The following is a description of a gene set: species: Mus musculus We combined large-scale mRNA expression analysis and gene mapping to identify genes and loci that control hematopoietic stem cell (HSC) function. We measured mRNA expression levels in purified HSCs isolated from a panel of densely genotyped recombinant inbred mouse strains. We mapped quantitative trait loci (QTLs) associated with variation in expression of thousands of transcripts. By comparing the physical transcript position with the location of the controlling QTL, we identified polymorphic cis-acting stem cell genes. We also identified multiple trans-acting control loci that modify expression of large numbers of genes. These groups of coregulated transcripts identify pathways that specify variation in stem cells. We illustrate this concept with the identification of candidate genes involved with HSC turnover. We compared expression QTLs in HSCs and brain from the same mice and identified both shared and tissue-specific QTLs. Our data are accessible through WebQTL, a web-based interface that allows custom genetic linkage analysis and identification of coregulated transcripts. Genes whose expression is coregulated with that of IL3RA in hematopoietic stem cells (HSC). Human Gene Set: BYSTRYKH_HEMATOPOIESIS_STEM_CELL_IL3RA from publication Bystrykh L, Weersing E, Dontje B, Sutton S, Pletcher MT, Wiltshire T, Su AI, Vellenga E, Wang J, Manly KF, Lu L, Chesler EJ, Alberts R, Jansen RC, Williams RW, Cooke MP, de Haan G (PMID 15711547), and this is the list of marker genes: GUCA1ANB-GUCA1A, CCND3, BCAP31, SERTAD1 (SERTA domain containing 1), PCDHA9, RAC1, EPHA6, KMT2A, VEGFB